Given this list of marker genes GPR137B, POM121, CRTC2, TMCC1, SLC25A29, POM121C, PIK3CA (NCBI Gene Id 5290), DZIP1, CEACAM19, POLDIP3, TSPAN18, ESPN, FAM219A, FAM53B, PHKG1, DRP2, TRIP12, ANKMY1, BCL9L, ERN1, TIMP3, SMAD3 (NCBI Gene Id 51521), SLC35F6, ALPG, CDH8, FBXL5, WDR48, CYB5RL (NCBI Gene Id 606495), MTCL2, SDK1, PENK, PAX5, USF2, UBR7, TYR, TPPP, CPLX2, ZNF677, IQSEC2, PARL, IQSEC3, CHTF8, RCAN2, KCNQ2, ATG7, ABLIM3, LOXL3, ATP1A3, SDC3, RASD2, GGA3, TMEM104, PRELP, FGF23, TRIM28, GNAZ, GNG13, NGFR, CSPP1, here is a description of the gene set: from publication Chen Y, Wang X (PMID 31504780) Genes predicted to be targets of miRBase v22 microRNA hsa-miR-6762-5p in miRDB v6.0 with MirTarget v4 prediction scores > 80 (high confidence targets). Human Gene Set: MIR6762_5P species: Homo sapiens